Given this list of marker genes Slc6a9, Slc38a4, Slc6a15, Slc38a7, Slc38a2, Slc38a3, Slc38a1, Slc6a5, here is a description of the gene set: species: Mus musculus Enables the transfer of a solute or solutes from one side of a membrane to the other according to the reaction: neutral L-amino acid(out) + Na+(out) = neutral L-amino acid(in) + Na+(in). Mouse Gene Set: GOMF_NEUTRAL_L_AMINO_ACID_SODIUM_SYMPORTER_ACTIVITY